Given this list of marker genes Ank2, Topbp1, Ywhag, Ank3, Lyn, Socs2, Nbn, Plcg2, Vav1, Socs7, Ptpn6, here is a description of the gene set: species: Mus musculus Binding to a protein upon phosphorylation of the target protein. Mouse Gene Set: GOMF_PHOSPHORYLATION_DEPENDENT_PROTEIN_BINDING